The following is a description of a gene set: Human Gene Set: HP_PSEUDOHYPOALDOSTERONISM A state of renal tubular unresponsiveness or resistance to the action of aldosterone. studied in species Homo sapiens Pseudohypoaldosteronism, and this is the list of marker genes: NR3C2, CUL3, KLHL3, SCNN1A, WNK4, WNK1